The following is a description of a gene set: from publication Chen Y, Wang X (PMID 31504780) Genes predicted to be targets of miRBase v22 microRNA mmu_miR_1947_5p in miRDB v6.0 with MirTarget v4 prediction scores > 80 (high confidence targets). Mouse Gene Set: MIR_1947_5P species: Mus musculus, and this is the list of marker genes: Ireb2, Fkbp10, Pcdh7, Ttc5, Dse, Jmjd8, Ccdc6